Given this list of marker genes UBE2K, RABL2B, PREPL, POGK, WSB2 (NCBI Gene Id 55884, WD repeat and SOCS box containing 2), PJA2, FOXO3 (NCBI Gene Id 2309), DYNC1H1, CHST10, ABI2, PPIG, MACF1, MTMR4, NCKAP1, ZFAND3, PHF10, NAB1, MYO10, CCDC92, MAP4K4, RAN, MFSD8, FAM219A, TRIM37, GOLGA7, GSTA4, KIF3B, CAND1, PHAX, BMPR2, VPS26B, STX12, CLEC16A, TBCK, IPO7, SESN3, MAGED4, ZNF275, CALM1, PHF2, RTN4, TMEM248, RALGAPA1, ASAP2, USP33, NDFIP1, SELENOI, FBXO21, VPS52, SPIRE1, NUP133, ADO, GSK3B, PHC1, RERE, RALGAPB, CSRNP2, FBXW11, STMN3, GPR107, ZNF84, DYNC1I2, POGZ, DLG5, TMEM30A, RMDN3, CLCN3, SNX27 (sorting nexin 27), KIDINS220, ACSL3, NGRN, GBA2, TSPYL4, NFIA, EXOSC6, PNMA8A, HERC2, CRKL, APPBP2, OAZ2, KIF1B, DDX17, FAM168B, WBP2, IQCK, here is a description of the gene set: Human Gene Set: GCM_BMPR2 Neighborhood of BMPR2 bone morphogenetic protein receptor, type II (serine/threonine kinase) in the GCM expression compendium Neighborhood of BMPR2 studied in species Homo sapiens